The following is a description of a gene set: Human Gene Set: HP_ABNORMALLY_SLOW_THOUGHT_PROCESS An inner sense from the self that thoughts are abnormally slow and the individual feels that they are unable to increase their rate of thinking. The primary pathology is the decreased rate and other qualities of thinking (e.g. naming of objects) are intact, just slowed. This may be associated with slowed speech, but may be internal and masked by speech that is limited to brief (yes or no) answers. Abnormally slow thought process studied in species Homo sapiens, and this is the list of marker genes: NOTCH3, SLC2A3, HTT, DMPK (NCBI Gene Id 60405), VPS13A, PRNP, CLTC